Given this list of marker genes SLC25A42, RNF181, CTRC, SELP, LAMC3, SPINK4, SFTPC (NCBI Gene Id 6440), IRX4, HIC2, RGS9, ZDHHC11 (zinc finger DHHC-type containing 11), TMEM150B, LONRF3, ZIC3, KCNQ1, FUT10 (NCBI Gene Id 84750), RMDN2 (NCBI Gene Id 151393), CD300C, TPSG1, BNIPL (NCBI Gene Id 192667), CNIH4, NKX6-1, PTPN5, ZHX3, GPAT2, MS4A13, HRCT1, LIF, PAQR6, PPFIA4, KRTAP15-1 (NCBI Gene Id 337962), HMGN5, PMP22, EFNA1, TSPAN7, SEMA5B, FAM83G, KRTAP2-4, CRYBA2, SLC46A1, RILP, RAB39B, TLX1, ACKR4, TRARG1, ST18, GRHL2, ASIC3, TEX13B, SORCS3, CHST2, HAS2, HES2, WFDC1 (WAP four-disulfide core domain 1), CSF1, PYGO1, PRR15L, LYPD6B, RELN, CCNA1, SERPINH1, C19orf73, ZNF532, CLEC12B, AGAP1, KRTAP20-2, OSBP2, P4HA3, AVPR2, HRH3, WFDC2, PLEKHH2, ZNF704, GLI1, NTN1, COL6A2, CFAP251, CCT8L2, RNF112, SPINK1, RFX4, LRRC75B, NUDT16L1, PTGDS, PDGFD, XIRP1, MMP8, KIF24, DCST1, GFAP, HAL, PDRG1, MASP2, ZNF239, SORBS1, PAX4, SSC5D, DUSP18, IFNB1, IL36B (interleukin 36 beta), HOXC6, MGAT4EP, TLCD1, GNAZ, C6, TFAP2A, KCNMB1, GABRR1, PHOX2B, PITPNM2, GJD2, COL4A2, MGAT2, RAB25, RETN, ANXA13, ME3, TMIE, ACP7 (acid phosphatase 7, tartrate resistant (putative)), KIAA1671-AS1, MAD1L1, AXIN2, FAT1 (NCBI Gene Id 2195), MYOM3, UBQLN3, PPIL6, THNSL2, TSSK3, OLFML1, CNGA2, ILKAP, LRMDA, ASPH, ZAR1, CCDC92, PRR27, CA5A, GRIN2A, GPA33 (NCBI Gene Id 105371599), SSUH2 (ssu-2 homolog), DLX6, CACNG8, CH25H, MUC5B, NPAS4, C12orf56 (chromosome 12 open reading frame 56), MACROH2A2, SNAPC5, SIDT1, RCOR2, BRSK1, CLDN19, GRM2, TBX18, TKTL2, SYT5, FOXI1, NLRP5 (NLR family pyrin domain containing 5), MMP9, LEFTY2, ALX4, PPAT, TIMP3, UPK3BL1, SNAI1 (snail family transcriptional repressor 1), GASK1B (NCBI Gene Id 83936), LLGL2, KIF12, PCSK9, FAM131C, GSG1L, IRS4, ARHGAP24, MFAP5, HRH4, CLTA, CD40LG, CYP8B1, MAP3K6, TRPM1, PCYOX1L, KRT32, ALB, JPH2, BVES, SCN2A, TBC1D2, CACNB1, LRP3, ADRA2B, RSPH9, LIMS2, LIPH, HMX1, TFAP2C, TTLL8, DPEP1, BIRC7, SEMA6A, MOK, here is a description of the gene set: To obtain insight into the genetic basis of the increase of functional activity of memory B cells over time, we compared the gene expression profiles of day 7 and day 40 NP-specific/IgG1 memory B cells, GC B cells and plasma cells in immunized WT mice and naïve B cells, before and after activation in vitro. Human Gene Set: GSE11961_MARGINAL_ZONE_BCELL_VS_MEMORY_BCELL_DAY7_DN studied in species Homo sapiens Genes down-regulated in marginal zone B cells versus day 7 memory B cells. from publication Kaji T, Ishige A, Hikida M, Taka J, Hijikata A, Kubo M, Nagashima T, Takahashi Y, Kurosaki T, Okada M, Ohara O, Rajewsky K, Takemori T (PMID 23027924)